The following is a description of a gene set: studied in species Homo sapiens Response of Mtb to phagocytosis Human Gene Set: REACTOME_RESPONSE_OF_MTB_TO_PHAGOCYTOSIS, and this is the list of marker genes: MAPK3, SFPQ, RAB5A, NOS2, GSK3A, ATP6V1H, ENO1, KPNA1, CTSG, RAB7A, CORO1A (coronin 1A), KPNB1, UBC, HGS, RNF213, RPS27A, DUSP16 (dual specificity phosphatase 16), UBB, MAPK1, TRIM27, PGK1, UBA52, VPS33B